Given this list of marker genes OAZ3, OAZ1 (ornithine decarboxylase antizyme 1), OAZ2, AZIN2, AZIN1, here is a description of the gene set: Any process that modulates the frequency, rate or extent of polyamine transmembrane transport. species: Homo sapiens Human Gene Set: GOBP_REGULATION_OF_POLYAMINE_TRANSMEMBRANE_TRANSPORT